The following is a description of a gene set: species: Mus musculus Any process that stops or decreases the rate or extent of glial cell proliferation. Mouse Gene Set: GOBP_NEGATIVE_REGULATION_OF_GLIAL_CELL_PROLIFERATION, and this is the list of marker genes: Cysltr2, Fas, Adcyap1, Nf1, Notch1, Hes1, Rb1, Abcc8, Dicer1 (NCBI Gene Id 68462), Cers2, Cdkn2b, Ptn, Sox11, Mfn2, Sox10, Idh2, Ski, Rnf10, Trp53, Ascl2, Tert, Nf2, Tspo